The following is a description of a gene set: The chemotaxis process that directs the migration of an axon growth cone of a dopaminergic neuron to a specific target site in response to a combination of attractive and repulsive cues. studied in species Mus musculus Mouse Gene Set: GOBP_DOPAMINERGIC_NEURON_AXON_GUIDANCE, and this is the list of marker genes: Vangl2, Wnt5a, Fzd3 (NCBI Gene Id 320969), Wnt7b, Ryk, Celsr3